Given this list of marker genes SELENOM (selenoprotein M), KCNQ1, TAC1, CRH, TSPO, ECRG4, CRHR1, POMC (NCBI Gene Id 5443, proopiomelanocortin), here is a description of the gene set: Human Gene Set: GOBP_CORTICOSTERONE_SECRETION The regulated release of corticosterone into the circulatory system. Corticosterone is a 21-carbon steroid hormone of the corticosteroid type produced in the cortex of the adrenal glands. species: Homo sapiens